The following is a description of a gene set: BACKGROUND: Visceral leishmaniasis (VL or kala azar) is the most serious form of human leishmaniasis, responsible for over 20,000 deaths annually, and post kala azar dermal leishmaniasis (PKDL) is a stigmatizing skin condition that often occurs in patients after successful treatment for VL. Lack of effective or appropriately targeted cell mediated immunity, including CD8+ T cell responses, underlies the progression of VL and progression to PKDL, and can limit the therapeutic efficacy of anti-leishmanial drugs. Hence, in addition to the need for prophylactic vaccines against leishmaniasis, the development of therapeutic vaccines for use alone or in combined immuno-chemotherapy has been identified as an unmet clinical need. Here, we report the first clinical trial of a third-generation leishmaniasis vaccine, developed intentionally to induce Leishmania-specific CD8+ T cells. METHODS: We conducted a first-in-human dose escalation Phase I trial in 20 healthy volunteers to assess the safety, tolerability and immunogenicity of a prime-only adenoviral vaccine for human VL and PKDL. ChAd63-KH is a replication defective simian adenovirus expressing a novel synthetic gene (KH) encoding two Leishmania proteins KMP-11 and HASPB. Uniquely, the latter was engineered to reflect repeat domain polymorphisms and arrangements identified from clinical isolates. We monitored innate immune responses by whole blood RNA-Seq and antigen specific CD8+ T cell responses by IFN-gamma ELISPOT and intracellular flow cytometry. FINDINGS: ChAd63-KH was safe at intramuscular doses of 1x1010 and 7.5x1010 vp. Whole blood transcriptomic profiling indicated that ChAd63-KH induced innate immune responses characterized by an interferon signature and the presence of activated dendritic cells. Broad and quantitatively robust CD8+ T cell responses were induced by vaccination in 100% (20/20) of vaccinated subjects. CONCLUSION: The results of this study support the further development of ChAd63-KH as a novel third generation vaccine for VL and PKDL. TRIAL: This clinical trial (LEISH1) was registered at EudraCT (2012-005596-14) and ISRCTN (07766359). studied in species Homo sapiens from publication Osman M, Mistry A, Keding A, Gabe R, Cook E, Forrester S, Wiggins R, Di Marco S, Colloca S, Siani L, Cortese R, Smith DF, Aebischer T, Kaye PM, Lacey CJ (PMID 28498840) Genes down-regulated in blood 24hr vs 0hr in adults (18-50) (high dose subjects) after exposure to ChAd63-KH, time point 24H, administered Intramuscular injection. Comment: DE gene list for high dose subjects. Human Gene Set: OSMAN_BLOOD_CHAD63_KH_AGE_18_50YO_HIGH_DOSE_SUBJECTS_24HR_DN, and this is the list of marker genes: TIAL1, CCDC171, TUBGCP3 (tubulin gamma complex component 3, NCBI Gene Id 10426), PTPN22, TRAJ21, B3GLCT, TGIF1, RNF216, FAM3D, PREPL, SH3YL1, RGS14, ATOSA, TMEM245 (transmembrane protein 245), ATF7IP, TIMD4, SNX9, GOLGA8R, PKIA, TGM3, SLC4A7, NRXN1, HS3ST3B1, RBM28, ASF1B, ZFP28, ZNF235, CERS4, SERGEF (NCBI Gene Id 26297), ZNF256, GPR174, ZC3H6, RP9, EIF4BP6, USP53, MCM3AP-AS1, CD200R1, ARL3, ARL14EP, MYBL1, FKTN, RCAN3, SPG7, ZNF425, MAP3K2, ARID2, REPS1, PIAS2, ZNF354C, NLRP12 (NLR family pyrin domain containing 12), BBS4, TRAJ6, P3H4, TEF, KAT14, SMYD3, SETD6, ZNF398, GSTM2, SPATA41, ERBB2, HSPD1P11, ASF1A, SNRNP48, JAKMIP2, MICU3, GPRASP3, IRS2, SLC5A3, MOAP1, ELOVL4, KMT5B (NCBI Gene Id 54794), NUCB2, DMAP1, TULP4, CCDC57, FAUP1, FBXL20 (F-box and leucine rich repeat protein 20), CD99, UAP1 (UDP-N-acetylglucosamine pyrophosphorylase 1), FANCG, MZT2A, CASS4, ANKRD55, LINC00426, SERINC5, ACBD6, GRAP, ZNF528, SPOCK2, TMC8, TCFL5, CSGALNACT1, NARS2, KLHL42, ZNF514, FAM171B, TDP1, POLR3B, RPS20, PABPC4, INPP5B, SLAMF6, TRGJ2, KLHDC2, BORCS5, XCR1, DENND4C, ZFAND1, SIRPG, SH3RF3, CFL2 (cofilin 2), ZNF786, COL5A2, RFLNB, USP12-AS1, UNG, AAK1, LRBA, LINC00243, BBS2, GNPDA2, NAPEPLD, LINC01619, RPH3A, RNU6-1305P, OR2L5, PRPSAP1, ZNF829 (NCBI Gene Id 374899), MRPS31, LINC00205, MTERF2, CCSER2, SNORA17B, ARGLU1, SCARNA6, LYVE1, TMEM25, C18orf54, TRAJ9, DENND2D, SPINT1, RWDD2A, CNPY4, CEP126, CENPV, DYRK2, AKT3, MMS22L, FRMPD3, CD96 (NCBI Gene Id 337949), TMEM116, DCAF17, H1-10-AS1, KBTBD11, RPL23AP53, PPARA, SMURF2, NOP53, ZNF746, SFT2D3, FAM168B, PIGL, RNF157-AS1, ELP2, SLC49A4, ZNF433, IL23A, CEP43, CDK5R1, BRD1, NDUFAF7, S100PBP, RNU6-1005P, ARL5A, KLHL7, FAM43A, BLM, SUGP2, FAM66C, LINC00680, TRIM52, RBKS, PM20D2, APBB1, ULK4, LRP6, YPEL1, CDC14A, ANKEF1, GPR27, POLR1HASP, ALMS1-IT1, LARP4P, TMEM204, DPY19L3, SPOCK1, AMIGO1 (adhesion molecule with Ig like domain 1, NCBI Gene Id 57463), OSBPL3, TRAT1, CD27, SPICE1, DHRS3, CACHD1, ZNF567, FAM110C, LINC00671, KRT73, IRAG1, ICOS, PEG10, IGIP, EPN2, MEGF6, ZCCHC18, KIF2A, NCR3LG1, TPP2, HNRNPH1, CEP57, RPS6KA3, MRS2 (magnesium transporter MRS2), TMEM263, CREBZF (CREB/ATF bZIP transcription factor), RO60, RNU4ATAC16P, TRAJ29, WDR33, SNRPFP1, DLG1, MCM8, NFATC2, ACVR2B, DHRS7, TRPC1, PSMG3-AS1, ACYP1, PRKCA, TTC23L, ZNF519, GCHFR, HLCS (NCBI Gene Id 3141), ZNF234, DNAJC19, TENM1, PLCL1, ZEB1 (zinc finger E-box binding homeobox 1), BRICD5, CABIN1, NBPF3, H1-3, AKTIP, GKN2, RAD54B, ZNF285, PEBP1, KIFAP3, HNRNPDL, PTCH1, RASA3 (NCBI Gene Id 22821), LINC02210 (long intergenic non-protein coding RNA 2210), PHLDB2, SCARNA11, CNNM3, NDUFAF6, ANO10, CUTC, ZNF852, MIR146A, PTGFRN, GGT8P (gamma-glutamyltransferase 8 pseudogene), PDE4DIP, ETS1, DSTYK, DDX20, DUS2, PROX2, BRPF3, MED28P1, GATA3, TRMT13 (tRNA methyltransferase 13 homolog), N4BP3, TUBE1, ZMYM2, TRIM9, TRAV5, C22orf39, RBFADN, RAD51-AS1, RNU6-759P, RASA2, IMP3, KLHL31, POLH, IRAG1-AS1, ST6GALNAC6, FBXL13, MORN4, WEE1, BICD1, ZSCAN2, RPGRIP1L, CD1E, PTGDR, ZNF30, RWDD3, TRAV12-1, PCNX1, ZBED4, KDM5B, ERMP1, TSGA10, HIP1R, ZNF566, SLC4A10, TRAV22, SWINGN, RASGRP1, ALG10, PNMA1, TAS2R10, RNU6-878P, PASK, ADGRD1, ADAM1A, TJP3, ZBTB20, DAPK2, LMLN, CTBP1-DT, ZNF827, SREK1, ATG2B, LEF1-AS1, ENOSF1, MLLT3, RASGRF2, ERP27, TBC1D32, RUBCNL, DNAJC24, STXBP5, ABCA17P, ICA1L, KRT8P42, TASP1, NEMP2, TGDS, CLDN12, CYCSP32, FZD3, ANKRD28, MID2, NISCH, PRKCH (protein kinase C eta), CBX7, FMC1-LUC7L2, COLGALT2, LIX1L, CST7, ME1, UNC45B, CNOT6, PPP4R4, TANC2 (NCBI Gene Id 80259), MTAP, SYCP2, URGCP, TESPA1, OCM, ICE2, TRAJ4, ZNF630, CALM1, TRAJ52, ZDHHC20P1, SHPRH, THRA, TRMT61B, SLC4A4, KLHDC1, HSF2, TARBP1, LINC00342, MPZL3, FNBP1P1, ZNF280D, TRAJ8, LZTS2, GOLGA6L9, CAMK2G, NUDT3, CFAP70, FAM66B, BHLHE40-AS1, KLRC1, RFC4, SLC16A14 (NCBI Gene Id 151473), PLB1, RPS6, ZNF839, ZNF529, PLXND1, KBTBD6, WWOX, ATP8A2, UBE2Q2P1, DPY19L4, ZNF850, TARS3, PARP2, HCG18, DPH7, CROCCP3, GLCCI1, TXK, RBFOX2, AGL, AK3, PROK2, ZNF420, SDR42E1, CA4, TRIM32, MTBP, CMC1, TRBV7-1, CMSS1, IFT88, MPPE1, YAE1, PGM2L1, TOP2B, CDH26, MIEF2, CEP44, VPS26AP1, CD3G, TMIGD1, ABLIM1, HGSNAT, DDX12P, RDH16, S1PR5, ZSCAN30, SLC25A40, CRTAM, ZNF530, PXYLP1, SPTBN1, RNU6-1, ZNF506, CRYZL1, LRP2BP, S100A2, PLCB1, TMEM161B, ZMYND11, ZBTB16, PRPF39, TTC5, SNORD116-21, MMP9, RAPGEF6, KRT8P33, SLC35D1, DPY19L2P4, UBE3D, FAM153A, ADGRE3, OFD1, ITGB4 (NCBI Gene Id 3691), DTHD1, RASSF1, ZNF101P2, ZNF569, RNU7-113P, ZCCHC14, N6AMT1, LEKR1, CD160, H4C5, RFX7, ZC3H8, STK39, RPL34-DT, TACC3 (transforming acidic coiled-coil containing protein 3), SKP2, LDHB, RAD1, PTPDC1, NAP1L1, ZNF329, SPATA6L, RANBP2, ZNF660, MAL, CMTM4, NRCAM, NSUN5P2, ZNF264, PDZD8, APCDD1, IFT27, RBL2, SOCS5, PRKCQ, RYK, TRAJ16, GPR34, CFAP44, ZKSCAN7, REV1, SLC25A36, APPL2, EXD2, USP45, ADHFE1, EIF3J-DT, TRABD2A, ZNF605, YLPM1, DLEU2L (deleted in lymphocytic leukemia 2 like), COLEC12, ZBTB44, INPP5A, ATL2, ZNF570, LIPT2 (lipoyl(octanoyl) transferase 2), RRH, CTPS2, MTA3, NEMP1, LIAS, SLC35B4, ABCA10, CD28, CYTH3, C5orf34, H1-2, ZNF793, TNRC6C, FAM162A, ZDBF2, MFSD4B, PCMTD2, MIR202, TRAF3IP3, TPRG1, FBXO25, TOGARAM1, AGO1 (NCBI Gene Id 26523), ALOX12B, ANKRD18A, DPEP3 (NCBI Gene Id 64180), ATP6V0E2-AS1, MIR17HG, ZFP14, SBNO1, AGO3, ASB1, ANKRD31, TESMIN, BAAT, KLHL22, TRIM37, SETP20, ERMARD, COX10-DT, ZNF204P, GOLGA8O, PPIAP30, MSANTD2, RNF157, IL32, RECK, CXCL8, WDR76, ABCG1, CREB3L4, ZNF577, ENDOV, MTRFR, TAS2R12P, PTDSS2, GPAM, MAST4, MGAT4A, XKR6, ZBTB1, OR10J2P, SNORD64, TRIM16, SRSF11, TCF19, AMY2B, ALG1L13P, SIM1, MIR4637, KLRF1, TAS2R40, LINC00683, SMARCA2, NBEA, INPP4A, GRPEL2, CATSPERB, CLYBL, CDON, PLEKHB1, CASP2, HELLS, GLMN, CCDC102A, TRAJ50, TMIGD2, GCFC2, RALA, ZNF426, DNAH6, DCHS1, FGF9, ARMC2, RGPD5, ALS2, PCYOX1, TCEA3, TBCD, ODF2L, ZNF815P, SRPK2, NR1D2, VEZT, ISM1, SIAH1, GJB6, DBF4, CDR2, NME6, FAM218A, SMIM8, NPM1P9, PPP2R2B, EIF3F, LDLRAP1, SPON1, ANGPT1, C12orf42, LPCAT1, RLN1, SLCO4C1, EHBP1, FKBP14, ABCC5, TRGJP1, PIGK, STAT4, RNU1-16P, EIF4B, ZNF767P, CILK1, USP48, EXTL2, PAFAH2, FGGY, ARL6, SCARNA17, LEP, MRTFB, PPIAL4D, PIGP, SAMD3, CNIH1, GPR183, ING2, MIR4779, DPP4, RN7SKP97, ZNF558, RFXAP, TRAJ27, WNT7A, TM6SF1, RSBN1, PGM2, RBBP4P1, RUFY2, TRAJ40, URI1, RNU6-821P, DIS3L, ADAMTS10, VAMP4, RPL13, C16orf74, KLRK1, DPH5, PLAG1, NPHP3, ENPP4, THBD, ZNF671, ZNF44, ZMAT1, IFFO2, IMPDH2, TRAJ47, CENPC, BTBD8, PPIP5K1, ZNF789, IRGM, NR2C1 (NCBI Gene Id 7181), NAA30, KLF12, LYRM7, CAMSAP1, FABP7P1, TUT4, ALG6 (NCBI Gene Id 94752), THEM4, TRAJ23, ZNF507, RCN2, LLGL2, ATF7IP2, GOLGA8B, LEF1, ZNF875, AXIN1, TBC1D7, TRAJ39, ABI2, ZNF799, CDC42BPG, STAG1, IL7R, EML5, NT5DC1, SGSM2, ZNF182, ITGA6, CAPN7, SLC39A10, PLAU, DIPK1A, DNAJC9, NIPSNAP3B, CCL5, DTD1, ZNF737, DEF6, MCM6, NLRC3, LINC00920, LRIG1, WWP1, SCAI, TRIM60P18, ZNF286A, ANKRD26P4, KCNJ5-AS1, SSBP2, XKRX, TYW5, WDR3, MEX3C, USP13, CNTNAP3, COL6A2, MFGE8 (NCBI Gene Id 54740), PRKCQ-AS1, DMKN, BDH2, THOC1, ZNF681, AGAP1, LINC00469 (NCBI Gene Id 283982), CA5B, RPL3P4, FAF1, PPIAL4A, NUCKS1, S1PR4, LCK (LCK proto-oncogene, Src family tyrosine kinase), SLC16A10, POLR1E, ASTE1, HABP4, HPCAL4, CEP250, ZNF157, ARMCX4, CHIC1, SNX18, RPL35AP26, YES1, GOLGA8A, MPHOSPH9, ARHGAP12, EPHX2, SNHG14, CCDC89, PANX2, ZNF266, ZBTB4, KLF7-IT1, ITM2A, GTPBP8, DZIP3, FCGBP, RNU6-838P, AKR1B1, IFT80, IGLV3-9, RADX, ZNF26, OGT, PTGR3, SPATA7, SNCG, ALDH7A1, XPA (NCBI Gene Id 7507), CFAP36, CROT (carnitine O-octanoyltransferase), IMMP2L, HACD2, CDHR3, VPS13A, PA2G4P4, TRAJ38, FEZ1, SKAP1, KLRC4-KLRK1, MAPK13, ST18, ANKRD36B, GAB3, DEF8, MSH3, INTS2, AKAP11, TBC1D19 (TBC1 domain family member 19), CD6, PROCR, MBIP, LINC00662, SRGAP3, ZBTB14, APMAP, SERF1A (NCBI Gene Id 8293), FOXO1, SMKR1, MRPS6, HAGHL (hydroxyacylglutathione hydrolase like), SNORD91B, ZBTB38, AHI1, TMEM45B, RRP8, ZNF792, SYTL2, HACD3, NAP1L2, CAPN14, ZNF823, LINC00299, RRN3P1, ZNF43, TRAJ26, ANKRD20A5P, UBE2Q2P2, IVNS1ABP, RRAS2, AGAP12P, ADCY9, EEPD1, UPB1, ZNF548, ADGRE4P, GOLGA2P5, DDX31, APBA2, TTC13, CYFIP2, CDIN1, ABAT, SNORA31, AHCTF1, DPY19L2, ATP2B4, LAX1, FAM219B, RNF125, EXOSC8, LINC00987, CDH2, TRPM6, CD3E, HLTF, VNN1, PGAP2, ID2, CEP83 (NCBI Gene Id 51134), ZBTB40, VPS26B, GZMA, FANCD2, KCNQ5, ANKLE2, MIR598, ZNF445, FYN, CASK, N4BP2, TIGIT, KHK, ZNF589, TRAJ17, SDC2, CDKN2B, EXOSC7, TRAJ55, GPRASP2, VN1R82P, SULT1A2, HNRNPU (NCBI Gene Id 3192), FAM216A, CCNB1IP1, ANKS6, MAGEE1, VPS51, STARD9, IGHV1OR15-1, EPM2AIP1, ACP6, GAS5, COX19, DIP2A, HMOX2, ZNF551, MME, PPARGC1A, CAMK4, NUBPL, DOCK3, EFHC1, LUC7L, KIF21A, NPAS2, NADK2, METTL24, BIVM, PEX5, C3orf33 (NCBI Gene Id 285315), TEX30, RETREG1, MAP9, PRMT7, COL9A3, KRT18P37, PRPF38B (NCBI Gene Id 55119), KATNAL1, AUH, OCIAD2, IDS, PARP16, CCDC7, TRAJ22, STAG3L1, NMT2, LINC00402, RNU1-22P, CHCHD6, ZNF248, TRAJ10 (NCBI Gene Id 28745), GNG2, C7orf25, GDF11, DOK4, YAF2, SUN2, C14orf28, FTX, ZNF718, ZNF90, CXCR6, FGFBP2, CEP78, ALDH6A1, RNVU1-15, HEATR5A, ABCA6, NBPF15, BTG1, PITPNC1, GFOD3P, MRE11, C1orf35, ANAPC1, MTMR2, PACS1, SNORD11B, PRKACB, CRYGS, MCEE, ZNF443, TLE1, C1QTNF3, SH3BP5, SEMA4F, TXNRD3, ATP5IF1, ASAH2B, CXCL6, EFHC2, LAMA2, RPL4 (NCBI Gene Id 6124), TMSB15B, ABCA3, LYPLAL1, ZNF304, ZNF600, LMO7, SAMD12, CASD1, PABPC1, BCL2, ATXN1, MAP3K4, CLEC2D, RNGTT, RGPD3, TSHZ1, PIK3IP1, A2M-AS1, PGM3, ZNF550 (zinc finger protein 550), PIK3R1, SPTAN1, STAU2, TRAJ48, GUSBP9, RPGRIP1, ZNF84, NAA16, CDRT4 (CMT1A duplicated region transcript 4), KRT72, PHF14, HOOK1, ARL4C, FAT4, HENMT1, ZNF286B, CHD3, IVD, GALNT14, INSC, KIF27, ATG16L1 (NCBI Gene Id 81560), MBLAC2, CCDC152, SNTB2, SLC25A53, ZNF449, BACH2, ZFYVE9, GOLGA8Q, FAHD2A, TRAF5, TMEM181, LCN12, ERMN, TRAJ19, CCDC92, EIF3EP1, PRKCZ, ATE1, HACE1, RPL4P1, PCM1, MINAR1, ABCD2, GABPB1-AS1, FSBP, ESPNL, SEC61A2, RNU6-1284P, ADAT2, ARSG, IGHVII-28-1, SEC22C, ZNF510, FITM2, NUDT6, TC2N, ZXDC, PYHIN1, PTS, KLHL3, TTC12, TRIM59 (NCBI Gene Id 353185), TUBGCP4, SLC16A1, ATP8B2, CD44, TSTD3, PCNX2, GTDC1, HNRNPCP1, KLRC2, POMT1, CBX1, MIX23P5, GRAMD2B, NEK11, NUMA1, RNU6-1240P, MIR4473, EPB41L4A-AS1, FGF7, BTBD7, TRAJ14, KLHL13, ZNF835, SCAND2P, ZNF549, HPGD, TRAF1, GCNT4 (glucosaminyl (N-acetyl) transferase 4), GFI1, RGPD8, TMEM117, COPS8, NBPF1, KIZ, PPWD1, PPP1R13B, SFMBT1, PLCXD2, CEP170P1, RPRD2, USP44, ATPSCKMT, BRI3BP, MKRN2, KPNA1, B3GNT2, PEX1, YAP1P1, ANKRD36C, PHACTR1, GPCPD1, CAMTA1, DPEP2, IFT57, DDX42, SPRED1, NDRG2, THEMIS, SUGCT, ARHGAP35, FAM169A, HS2ST1, FGFBP3, ZNF331, FAM161A, ATG9B, SEC63, ZNF382 (zinc finger protein 382), TRAJ1, SEL1L3 (NCBI Gene Id 23231), ZNF721, TSPYL4, CEP290, DRC12, PLEKHA5, TNPO1P1, THOC3, KLRB1, KIAA0319, ACAD8 (NCBI Gene Id 27034), ZNF10, ZNF616, DACH1, MTX3, VWA8, CBLB, IMPG2, TMEM14A, MAGEF1, ADAM23, TRAJ18, NCALD, COQ8A, PHF24, CD244, FBXL17, LSM11, SGK1, RNF141, NKTR, TMCO3, MST1P2, ZNF69, RAP1GDS1, RNF216P1, BRWD1, DSTN, BIN1, MSI2, IMPA2, ANKRD6, C5orf63, STXBP1, ADGRG1 (NCBI Gene Id 9624), SPAG16, WDR35, RPL3, PRMT9, TMC6, PIBF1, ADAM19, IL1RL1, ENO2, TOB1, TRGJP2, COG6, SFXN1, LANCL1, TMEM185A, SNX25, CFAP97, TRDMT1, MIR646HG, SYNE1, PCED1B, TMEM41B, DSC1, SYTL1, TRAV4 (T cell receptor alpha variable 4), PLEKHF1, CCDC141, GUF1, ANKZF1, ZFP62, DNM1P47, CPNE2 (copine 2), SPP1, NUDT13, ZNHIT6, FBXO32, DDHD2, SUGT1P3, SNRPN, SNHG6, RUNX2, MRI1, GRIK3, JUN, PRKG2, HNRNPA1P5, TOX, PGPEP1, EDAR, SFI1, DNAJC3-DT, LINC01550, FBXL4, SBDSP1, PADI4 (NCBI Gene Id 82795), EFCAB7, EFCAB5 (NCBI Gene Id 374786), NPAT, DLG2, LZTFL1, KLRC3, CNTNAP3B, SATB1, NAP1L3, OSGEPL1, ADAM22, KRT8P34, RFX3, AASDH, RORA, REV3L, RPL13AP25, USP47, RAB40B, ZBTB25, AMOT, LTK (leukocyte receptor tyrosine kinase), BCL11B, INPP4B, ZBTB10, ZNF337, UBR3, TPD52, TSPYL2, MYO16-AS1, KLRG1, GPATCH11, ZNF85, GALNT7, ZNF544, ZNF138, RPL37, TRAV38-2DV8, PON2, EZH1, PIRAT1, DPY19L2P2, CYCSP34, FAM98B, CCDC125, CEP170, TRAV16, MAGEH1, ALOX12P2, CALCB, CEP120, SLC38A1, AUTS2, TM7SF3, ZNF318, DPH6, ELP1, IKZF5, ADGRA3, EPHA4, OXCT1, ARSK, FAM185A, DMAC1, IPO11, PARD6A, RRM1, ZNF568, HMCES, NPRL2, HOPX, NCR1, RAB39B, THADA, NAA35, C1orf21, RIC8B, CCDC102B, CUBN, CD2, CYP4F12, FAM184A, PPM1H, KLF3, MBTD1, CD247 (CD247 molecule), C6orf163, PCBP4, ZNF608, MIR4720, SLC26A11, DLGAP1-AS1, RPL23A, ADAMTS1 (NCBI Gene Id 9510), PHLDA1, KIF22, RTL10, PRKN, DEPTOR, PANK1, SYDE2, ZNF343, TOM1L2, SDHAP3, IQCH-AS1, TRMO, PRSS30P, THNSL1, RTTN, TMX4, ZFP30, EEF2K, GSTA4, KIT, NSUN5P1, RNU6-820P, CD8B, CBR4, ARHGEF9, ZNF326, AGO2 (NCBI Gene Id 286109), MOSMO, ADAMTS5, SERF1B, NSUN7, GZMK, DLEC1, PPP3CA, ZNF781, PPP3CC, TTC3, ADSS1, PRSS23, PDE3B, TRAJ24, PLEKHM3, TRBV23-1, IPP, SFXN5, ESYT2, MYB (MYB proto-oncogene, transcription factor), POGLUT2P1, KLHL36, FCMR, GLS2, TSTD1, STARD13, WDR19, NECAB2, MYO9A, TTC28, TMEM91, PLD1, PHOSPHO2, KAT6B, MLH3, ZNF573, GPRASP1, FUT8, CHD6, CILP, ACADSB, ZNF599, SEMA4C, SNHG10, TRAJ57, GMCL1, PDGFD, ATP8A1, ADD3, OXNAD1, DNMBP, RIC3, FBXW2, FOXP1, KIF5C, SERTAD2, RNU7-130P, OR2A9P, H2AZ2, CEP70, TBL1XR1, ZNF416, DENND11, CXCL1, OVGP1, ST8SIA1, EIF3L, TRAJ5 (NCBI Gene Id 28750), ZZZ3, SHF, LONP2, NAF1, DGKE, TMEM67, ZNF232, DIXDC1 (DIX domain containing 1), CYREN, PHF10, DGKD, IKZF2, TRAJ51 (T cell receptor alpha joining 51 (pseudogene)), MIR491, UPF3A, TSPAN6, RPS3, SNORD108, MACF1, MMP23B, CHD1L, KDM3A, RAD23BP1, CCDC136, COL13A1, ABCA5, DBP, LRRN3, TRGV10 (NCBI Gene Id 6984), PTBP2, HOXB-AS3, SNORD109A, AGFG2, STRBP, MTUS2, CARF (calcium responsive transcription factor), ZNF345, REST, MANSC1, PAIP2B, SH2D1A, DAAM1, GK5, RPS3AP34, LRCH1, FCHO1, RPL5, IER5L, MTERF4, RAB33A, TTC28-AS1, ARHGAP10, FRA10AC1, ZNF483, MATK, AEBP2, BOK-AS1, EEIG1, GRAMD1C, ZNF891, CEACAM19, UBXN7, PSIP1, DCP1B, ZNF585B, ZAP70, BBS9, RPAIN, ZNRF3, ZNF846, GPD1L, HSPBAP1, ASPH, TMC2, CCDC191, MORN3, TMEM107, HIBCH, ORMDL1, ARHGEF7, ATP6V0A2, TMEM168, HLF, CYP2D8P, MATCAP2, LGR6, NEK6, DKK3, ABCB1, ACAD11, COX11, RNU7-90P, ZYG11B, UBTF, BDNF-AS (BDNF antisense RNA), FALEC, TRBV6-1, CD1C, FAM217B, EOMES, RNU1-109P, GTF2IRD2B, TRAJ33, NDRG3, SNHG1, RRM2P3, NIPA1, ZNF662, ADK, KLF8P1, PMS1 (PMS1 homolog 1, mismatch repair system component), PLEKHA1, GPALPP1, TTLL5, BMS1P4, SNURF, CRY1, RPL13A, HTRA1, PCID2, ERN1, B4GALT6, BAG2, BNC2, FIGNL1, AFG2A, XPC, PRKAB2, COQ10A, DEPDC7, TTC9, CTSF (cathepsin F), TRDD3, OTUD3, FBXO3, TBC1D4, ACACB, IL16, POLG2, ZMAT3, TADA2B, STAG3L3, C14orf132, DNAJC21, PARD6B, CYP27A1 (NCBI Gene Id 1593), ANKRD36, ZNF780B, ZNF546, TRAV18, NELL2, SLC25A29 (NCBI Gene Id 123096), MGAT5, CR1, CCDC14, KCTD7, MRPL46, KIF3A, BCR, ITK, ITPKB, SLC35E2B, TRAV3, CRIM1, ZNF561, PDE4D (phosphodiesterase 4D), WDR54, ARL10 (NCBI Gene Id 387489), GEMIN8, VSIG1, RNF43, GPA33, ZNF250, OSGEPL1-AS1, ZNF623, DLGAP1-AS2, ZNF540, CD40LG, KRT36, UFSP2, KLHL32, RN7SKP198, ZNF33B, CBY1, NHERF4, TDRKH, TET1, ANTXRLP1, KLRD1, RPL13AP20, ZNF607, PLCD1, TKTL1, SAMD10, DZANK1, CCNJL, DANCR, IFT172, METAP1, SEPTIN7P2, IQCC, VAPB, CEP85L, MIR181A2HG, FBXO47, MPRIP, ZNF571, TRAJ56, STXBP5-AS1, DDIT4, ZNF502, NR3C2, NOG, AMPD3, ARHGAP15, STAG3L2, TCF7, SULT1B1, ZNF862, GAN, KIAA0586, PCNX4, BBS10, ZNF649, ZNF154, CPSF6, SLC12A2, DGKA, SLC41A1, UBA5, TRIT1 (NCBI Gene Id 54802), ZNF559, PDE7A, GINS4, B3GALT2, GOLGA8S, DPY19L2P1, PRKDC, AMDHD1, ZNF17, ERCC6, RPL14, FAN1, LDLRAD4, KAZN, ZNF439, SPTSSB, FOCAD, PXK, ERCC6L2-AS1, PAXBP1 (NCBI Gene Id 94104), STMN3, HADH, NAE1, SLC19A2, PKIB, RCOR3, GPRIN3, TSEN2, SKI, ARMCX5, POU6F1, TRAJ31, TTC8, MIAT, ANKRD46, CEP68, SETP16, AGTPBP1, UXS1, SACS, NEO1, DGKG, RN7SKP110, ATM, RNF103, OR9A3P, PPP1R12B, FILIP1L, TRAV12-3, ZNF584, LRP1B, ELAPOR2, NMUR1, TP53INP1, MYO5A, ZNF554, ANKAR, MBNL2, ZNF354B, TRAJ20, HAVCR1, RPAP2, WDR86-AS1, ZNF461, MINDY2, AJAP1, KLRA1P, HDAC2, SCRN2, SMYD4, RBM26, CNKSR2, XYLT1, TUBGCP5, TDRD3, MYC, ZFP2, SSH1, RHOT1P1, ZNF615, EXOSC2, RTL6, SUPT3H, NEXMIF, ACVR2A, ZNF780A, ZNF7, TGFBR3, CEP95, SPEF2, JMY, CHMP7, SLAIN1, SAMD13, PODXL2, RLN2, ZNF497, AK5, ZSCAN18, LINC00861, TDRD15, WDR27, KIAA0753, PYROXD2, GALNT12, TBC1D10C, VIPR1, ZNF251, RNU6-202P, FAM107B (NCBI Gene Id 83641), ZNF484, C12orf57 (chromosome 12 open reading frame 57), TMEM161B-DT, CYBRD1 (cytochrome b reductase 1), AP3M2, IL9R, ALG13, SLC35G1, RALGAPA1, LIMA1, FLNB, GLIS3, ZBTB5, OSTCP8, DSEL, CDNF, ZNF831, TRGJP, ZNF805, KLF8, MSH2, CCDC65, TAS2R30, SUN1, MAPK8, RPL35AP19, JADE1, TRBV5-3, BFSP1, ZNF253, TBX21, ZNF71, RARS2, ZHX3, CBX8, SOX4, PDP2, SLC7A6, ZNF254, RPL13AP5, RNU6-414P, DYNC2H1, SLC16A7, LRRC7, CCN3, MNAT1, ABHD17C, SLC9B2, PPIAL4G, CTNNBIP1, PTPN4, TGFA, PMFBP1, LUC7L3, TRAJ12, PECR, PATJ, ADNP, TNNC1, PLCH2, WDR91, ENPP5, BBS1, RANP8, STXBP4, ANKRD26, DYNLT2, S1PR1, ZNF527, ZNF699, UNC119B, CPAMD8, LY9, ZNF37BP, CERK, BRME1, NSG1, BEND7, SPIN1, GOLGA7B, SESN1, RGPD6, DCUN1D2 (defective in cullin neddylation 1 domain containing 2), PURA, IFNG-AS1, BCKDHB